The following is a description of a gene set: part of: Signaling by NOTCH2 species: Homo sapiens Reactome Pathway: NOTCH2 Activation and Transmission of Signal to the Nucleus Similar to NOTCH1, NOTCH2 is activated by Delta-like and Jagged ligands (DLL/JAG) expressed in trans on a neighboring cell. The activation triggers cleavage of NOTCH2, first by ADAM10 at the S2 cleavage site, then by gamma-secretase at the S3 cleavage site, resulting in the release of the intracellular domain of NOTCH2, NICD2, into the cytosol. NICD2 subsequently traffics to the nucleus where it acts as a transcription regulator. <br><br>While DLL and JAG ligands are well established, canonical NOTCH2 ligands, there is limited evidence that NOTCH2, similar to NOTCH1, can be activated by CNTN1 (contactin 1), a protein involved in oligodendrocyte maturation. MDK (midkine), which plays an important role in epithelial to mesenchymal transition, can also activate NOTCH2 signaling and is able to bind to the extracellular domain of NOTCH2, but the exact mechanism of MDK-induced NOTCH2 activation has not been elucidated., and this is the list of marker genes: PSENEN, UBB, NOTCH2NLB, PSEN1, NOTCH2NLA, PSEN2, NOTCH2NLC, JAG1, JAG2, NOTCH2, MDK, NEURL1B, UBC, RPS27A, DLL4 (delta like canonical Notch ligand 4), DLL1, CNTN1, APH1A, UBA52, APH1B, ADAM10, NCSTN (nicastrin), NEURL1, MIB1, MIB2